The following is a description of a gene set: Human Gene Set: GOMF_PHOSPHOLIPASE_A2_INHIBITOR_ACTIVITY species: Homo sapiens Binds to and stops, prevents or reduces the activity of phospholipase A2., and this is the list of marker genes: ANXA1, ANXA2, ANXA8, SCGB1A1, ANXA3, PLA2R1